Given this list of marker genes MTCH2, EXT1, KIT (KIT proto-oncogene, receptor tyrosine kinase), GPLD1, CCR2, JAM2, GAS6, PTPRC, BCL11B, JAM3, here is a description of the gene set: Human Gene Set: GOBP_HEMATOPOIETIC_STEM_CELL_MIGRATION The orderly movement of a hematopoietic stem cell from one site to another. A hematopoietic stem cell is a cell from which all cells of the lymphoid and myeloid lineages develop, including blood cells and cells of the immune system. species: Homo sapiens